The following is a description of a gene set: The Emu-myc transgenic mouse has provided a valuable model for the study of B-cell lymphoma. Making use of gene expression analysis and, in particular, expression signatures of cell signaling pathway activation, we now show that several forms of B lymphoma can be identified in the Emu-myc mice associated with time of tumor onset. Furthermore, one form of Emu-myc tumor with pre-B character is shown to resemble human Burkitt lymphoma, whereas others exhibit more differentiated B-cell characteristics and show similarity with human diffuse large B-cell lymphoma in the pattern of gene expression, as well as oncogenic pathway activation. Importantly, we show that signatures of oncogenic pathway activity provide further dissection of the spectrum of diffuse large B-cell lymphoma, identifying a subset of patients who have very poor prognosis and could benefit from more aggressive or novel therapeutic strategies. Taken together, these studies provide insight into the complexity of the oncogenic process and a novel strategy for dissecting the heterogeneity of B lymphoma. Genes correlated with the early tumor onset in the Emu-myc transgenic mouse lymphoma model. Human Gene Set: MORI_EMU_MYC_LYMPHOMA_BY_ONSET_TIME_UP species: Mus musculus from publication Mori S, Rempel RE, Chang JT, Yao G, Lagoo AS, Potti A, Bild A, Nevins JR (PMID 18922927), and this is the list of marker genes: UHRF1, MOAP1, TRAF5, INKA1, AKAP12, UBE3D, IGF2BP3, CBX2, RNF2 (NCBI Gene Id 6045), ELOVL6, MCM7, SPAG5, SMARCA4, TOPBP1, KIF18B, TIPIN, CISD1, TRIB2, INIP, PLEKHA2, TRAF4, CHCHD10, FANCM, SNRPB, POC1B, CPLX2, COX5A, EIF4EBP2, SAPCD2, WDHD1, CDK1 (cyclin dependent kinase 1), OTUB2, SUMO2, AHCY, MMS22L, HMGA1, PCLAF (PCNA clamp associated factor), DNAAF2, CBX1, LLGL1, GCLC, ZBED3, STRBP, PIDD1, PHB2, CBLL1, LGALS9, H1-3 (NCBI Gene Id 3007), JMJD4, LSM6, MED9, PRIM2, RANBP1, PDE2A (phosphodiesterase 2A), MRPS18A, RFC3, PRDM4, ELOF1, INO80E, SMC1A, CENPS, BCAT1, DCK, ZNF428, FAM20B, CACTIN, DDX47, SMARCD2, EBF1, BLMH, AGK, SMARCB1, RBMX, TYSND1, SYNJ2BP, EFTUD2, SMPD4, MYB, HPRT1, SSRP1, FKBP3 (NCBI Gene Id 2287), U2AF2, CDCA4 (cell division cycle associated 4), SF3B6, RBBP4, TRIM28, MTHFD1, TCF3, CEP89, SHMT1, DAB2IP, SRSF2, CENPO, ERH, MUTYH, LIG1, RAI1, SEPHS1 (selenophosphate synthetase 1), BUB1B, PTGR1, MDM1, AKT3 (NCBI Gene Id 26068), DYRK2, MIS18BP1, SUZ12, CENPN, GEMIN5, CDK9, GINS2 (NCBI Gene Id 51659), FAAP24, ILF3